Given this list of marker genes SCN11A, GHRL, GHSR, TACR2, KIT, HTR2B (5-hydroxytryptamine receptor 2B), HTR1D, PTGER3, here is a description of the gene set: A process in which force is generated within smooth muscle tissue, resulting in a change in muscle geometry. This process occurs in the intestine. Force generation involves a chemo-mechanical energy conversion step that is carried out by the actin/myosin complex activity, which generates force through ATP hydrolysis. The intestine is the section of the alimentary canal from the stomach to the anal canal. It includes the large intestine and small intestine. species: Homo sapiens Human Gene Set: GOBP_INTESTINE_SMOOTH_MUSCLE_CONTRACTION